Given this list of marker genes KLHL24 (kelch like family member 24), SYK, TUBB2B, HNRNPA1, DOP1B, CR1 (NCBI Gene Id 1378, complement C3b/C4b receptor 1 (Knops blood group)), CD22, SPINK2, CCN2, SLC35E1, USP36 (ubiquitin specific peptidase 36), AIRIM (AFG2 interacting ribosome maturation factor), ZNF329, C11orf21, HCN4, IGLL3P, JAM3, PLXNC1, KYAT1, ABCD4, MAT2A (methionine adenosyltransferase 2A), RNASET2, LOXL2, SLC5A1, KCNE5, H2AC18, NEK9, PKD1L1-AS1, CD83, MAP2K6, TRAPPC2, SLC35E2B, TP63, ZNF804A, SIDT1, SIAH1, TRMT2B, ZNF202, PABPC3, OPN3, EFCAB14, YIPF1, ADAM28 (NCBI Gene Id 27337), FARP2, RABGEF1 (RAB guanine nucleotide exchange factor 1), SLC15A3, JADE3, ZCWPW1, CD52, ESM1, SYBU, PNOC, ENTR1, PIK3IP1, MUC5AC, MFSD1, GIT2, MAT1A, GNB5, HCP5, PLAC8, S100A5 (S100 calcium binding protein A5), TCL1A, LCMT2, TNFRSF13B, MCF2L-AS1, SNX3, BACE2, PRKAB1, ALDH2, MKKS, CRIP2, SPIB, CHMP7, IRS2, CD1C, CEPT1, LPCAT3, MAGED2, STS (NCBI Gene Id 6802), IL27RA, ADPGK, B3GAT1, FETUB, DAZAP2, MAGEC1, RGL2, PPM1F, FBXO21, PRRG3, CAT, ADCY9, PHF1, RALGPS2, SLC9A2, NPIPA1, BEX4, GVINP1, SPINT2, DGKD, MUTYH, CDC14A, RAP1GAP2, ZNF155, ZSCAN18, FAM30A, CTCF, AMPD2, SLC6A16, CD200, TTC19, TCTA (NCBI Gene Id 6988), ZNF510, SLC36A1, PATZ1, TFEB, CCDC170, GSE1, IFNAR2, STAT6 (NCBI Gene Id 6778), PLEKHF2, REPIN1, HPS1, SIDT2, ZHX3, SLC25A4, MORF4L1, UQCC1, RPS17P5, CA2, CUZD1, ADRB2, NCF1C, ZNF385D, NACA, ST13, STAMBPL1 (NCBI Gene Id 57559), CRIP1, GUSBP11, NPPC, SGSM3 (small G protein signaling modulator 3), TMUB2, REPS2, LYL1, PTGS1, SLC19A4P, DUS2, MEF2C, TMEM8B, NCK2, FOXO1, LTA4H (leukotriene A4 hydrolase), MZF1, TULP4, ALDH5A1, BBS1, ZNF211, HUS1, RUBCNL, SLC5A5, DPH5, PSG9, RAB36, SCPEP1, RNFT2, VPS11, LIN37, HLA-DRB6, PSD3, ESS2, TLR7, HCK, ARHGEF4, CD300A, DACT1, MUC7, TRHR, FA2H, TAGLN, RAB4A, TCFL5, PDLIM4, WDR77, CDK5RAP3, FMO1, UCN, SRPK2, MYO16, RAPGEF5 (Rap guanine nucleotide exchange factor 5), DLK1, LINC02981, GATM, CNPY3, FCGR2C (Fc gamma receptor IIc (gene/pseudogene)), CPLANE1, LAMC1, CSGALNACT1, PLPP3, NDST2, here is a description of the gene set: species: Homo sapiens from publication Jeffrey KL, Brummer T, Rolph MS, Liu SM, Callejas NA, Grumont RJ, Gillieron C, Mackay F, Grey S, Camps M, Rommel C, Gerondakis SD, Mackay CR (PMID 16474395) Genes up-regulated in comparison of B cells versus Th1 cells. In the present study we used Affymetrix oligonucleotide microarrays to produce gene transcription profiles for the major leukocyte types in humans. This comprehensive dataset enabled us to not only establish which genes were expressed in each leukocyte type, but also which genes were expressed in each subset after activation. The used of a comprehensive dataset of gene profiles from all the major human leukocyte subsets enabled a novel and powerful means for identification of genes associated with single leukocyte subsets, or different immune paradigms. Human Gene Set: GSE3982_BCELL_VS_TH1_UP